Given this list of marker genes DNHD1, DNAH1, DNAI3, DNAH2, DNAH7, DNAH3, here is a description of the gene set: Human Gene Set: GOCC_INNER_DYNEIN_ARM species: Homo sapiens Inner arm structure present on the outer doublet microtubules of ciliary and flagellar axonemes. The structure of inner dynein arms is complex and may vary within the axoneme. Inner dynein arms are heteromeric, comprising 8 different heavy chains and various subunits. Inner and outer dynein arms have different functions in the generation of microtubule-based motility.